The following is a description of a gene set: Reactome Pathway: Platelet degranulation part of: Response to elevated platelet cytosolic Ca2+ studied in species Mus musculus This event has been computationally inferred from an event that has been demonstrated in another species.<p>The inference is based on the homology mapping from PANTHER. Briefly, reactions for which all involved PhysicalEntities (in input, output and catalyst) have a mapped orthologue/paralogue (for complexes at least 75% of components must have a mapping) are inferred to the other species. electronically inferred by orthology from the curated human pathway, and this is the list of marker genes: Psap, Tln1, Orm2, Pcyox1l, Srgn, Pdgfb, Hrg, Fgg, F13a1, Vegfa (vascular endothelial growth factor A), Itih4, Tuba4a (tubulin, alpha 4A), Chid1, Brpf3, Aplp2, Calm1, Ahsg, Cd109, Itga2b, Islr, Tmsb4x, Ctsw, Itih3, Mmrn1, Pros1, Alb, Vegfc, Sytl4, Pcdh7, Cdc37l1, Tex264, Rarres2, Timp1, Ly6g6f, Orm1, Plg, Kng2, Vegfb, Pdgfa, Lhfpl2, Tgfb1, Serping1, Cd36, Aldoa, Selp, Rab27b, Gas6, Pf4, Tor4a, Apoa1, Igf2, Spp2, Scg3, Tmx3, Gtpbp2, Apoh, Lgals3bp, Nhlrc2, Cfd, Cd9, Lamp2, Vegfd, Sparc (secreted acidic cysteine rich glycoprotein), Abcc4, Trf, Serpinf2, F8, A2m, Hgf, Fam3c, Maged2